The following is a description of a gene set: studied in species Homo sapiens Systems vaccinology has emerged as an interdisciplinary field that combines systems wide measurements and network and predictive modeling applied to vaccinology. Here we used the systems vaccinology approach to study the molecular mechanisms underlying the innate responses to the trivalent inactivated influenza (TIV) and live attenuated influenza (LAIV) vaccination in humans, and to identify early gene signatures that predict the magnitude of the antibody responses to influenza vaccination. from publication Nakaya HI, Wrammert J, Lee EK, Racioppi L, Marie-Kunze S, Haining WN, Means AR, Kasturi SP, Khan N, Li GM, McCausland M, Kanchan V, Kokko KE, Li S, Elbein R, Mehta AK, Aderem A, Subbarao K, Ahmed R, Pulendran B (PMID 21743478) Human Gene Set: GSE29614_CTRL_VS_DAY3_TIV_FLU_VACCINE_PBMC_DN Genes down-regulated in comparison of peripheral blood mononuclear cells (PBMC) from TIV influenza vaccinee pre-vaccination versus those from day 3 post-vaccination., and this is the list of marker genes: DNAH9, GRIK2, COL5A2, TMEM254-AS1, CFAP20 (cilia and flagella associated protein 20), TTK, SSU72L6, IZUMO1, OPN1SW, DMGDH, PLCZ1, ADAMTSL2, OR7C1, DPP10-AS1, SMIM17, GPHB5, KHDC1, PFKFB2, LINC00472, DYNLT2, SLC39A2, RELN, SPMIP6, C3P1, DENND2B, SYMPK, CFAP300, KIF26A, LINC00051, PDX1, CBX2, HTN3, SH2D6, MVK, HBBP1, HHIPL1, AMN, AKAP8L (NCBI Gene Id 26993), LYNX1, AVPR1A, PKP4-AS1, PPP4R3C, DNAI1, ZNF112, LINC00906, SPIC, TGM4, ENSG00000245651, TMC2, KIF28P, CABP1, FRZB, BRSK1, TTC23, NCAPG, OR2F2, ENSG00000263547, ADAMTSL4, KCNIP1, C1orf167, ZNF257, ANKS1A, CBLC, MYL3, LINC02003, KSR2, BRINP2, SLC22A1, RGMB-AS1, ZNF436-AS1, FAM83B, SRARP, SEMG2, C20orf144, PHF8, DNAJC25, SYCE3, CRYBB1, WDR62, AHSA2P, LEISA1, MIXL1, POU4F1, SLC22A8, DPY19L2P3, LINC02226, BTF3P11, PRR7-AS1, PCGEM1, FRY-AS1, CFAP47, PAX2 (NCBI Gene Id 5076), ANO4, CHRD, SPATA31E1, CSN1S1, SLC25A5-AS1, PRR22, PDLIM3, S100A7A, HBZ, ABRA, GLI2, PHYHIPL, DCAF15, PRR35, FSD1, OR2B2, SEPTIN4, DACT3, STEAP1, GLIS1, KCNIP4, RTP5, EXD3, RBM26-AS1, CNTNAP3, SMTNL2, MMP24, FABP4, PLA2G2E, CCDC81, NAB2, GPR156, LRRC3, CUL1, ASIC5, CCDC7, TSPO2, MAP3K4, SLC5A8, MIR124-2HG, NKAIN2, DIPK1C, RFESD, OR52A1, SPC24 (SPC24 component of NDC80 kinetochore complex), ZNF334, SMC1B, ABCA8, GINS2, GULP1, ETNK2, APLP1, FRMPD4, BFSP2, EOLA2, SEMG1, PRKACG, CDH4, TOR1AIP2 (NCBI Gene Id 64163), ATP8B3, SHROOM2, HCCAT5, B3GNT6, DGKH, TRAPPC1, KCNB1, C4orf46, H4C9, PRPF38A (NCBI Gene Id 89466), TMEM52B, LINC00870 (NCBI Gene Id 201617), DMBT1, GPR37, USHBP1, CD2BP2, TMPRSS11E, ENSG00000261070, UPP2, ANXA13, GRHL2 (NCBI Gene Id 79977), SOX11, DMD, PAX1, H2BC13, HSPA5, DTL, HTR5A, HOXD8, TEX19, STXBP5L, CPNE9, RNASE7